Given this list of marker genes PRMT2, CALR, ZBTB7A, TCF21, KDM4C, KDM1A, NSD1, EP300, PKN1, SNW1, WIPI1, FOXP1, KDM3A, RNF14, ARID5A, SMARCA4, DDX5, PRKCB, DAXX, RNF6, PARK7, TRIM68, TMF1, TGFB1I1, KDM5D, FOXH1, here is a description of the gene set: Binding to a nuclear androgen receptor. Human Gene Set: GOMF_NUCLEAR_ANDROGEN_RECEPTOR_BINDING studied in species Homo sapiens